Given this list of marker genes HCK, IL12RB1, ARPC1B, SYK, TBK1, PGM3, C1QB, TREX1 (three prime repair exonuclease 1), here is a description of the gene set: Human Gene Set: HP_VASCULITIS_IN_THE_SKIN studied in species Homo sapiens A type of vasculitis (inflammation of blood vessel walls) that affects skeletal muscle tissue. Vasculitis in the skin